The following is a description of a gene set: species: Homo sapiens Any process that stops, prevents, or reduces the frequency, rate or extent of the directed movement of lipids within cells. Human Gene Set: GOBP_NEGATIVE_REGULATION_OF_INTRACELLULAR_LIPID_TRANSPORT, and this is the list of marker genes: MIR185, MIR17 (NCBI Gene Id 406952), MIR27B, ABCA2, PCSK9